Given this list of marker genes Rtel1, Lrwd1, Meaf6, Asf1a, Gtpbp4, Ddx11, Enpp7, Atf1, Noc3l, Etaa1, Ssbp1, Mcm5, Rmi2, Wrn, Tspyl2, Primpol, Poli, Nasp, Rpa2, Mapk15, Cdc6, Tk1, Orc1, Mgme1, Polq, Actl6a, Rpain, Twnk, Brca1, Lig3, Orc6, Prim1, Chtf8, Pclaf, Setmar, Eme2, Gmnc, Rbbp7, Fhit, Nucks1, Mcm4 (minichromosome maintenance complex component 4), Recql, Dtd1, Nuggc, Mus81, Polk, Rad51, Mcrs1, Supt16, Pole4, Upf1, Cdk9, Rfc4, Rad17 (NCBI Gene Id 319242), Ruvbl2, Polg2, Mas1, Ilkap, Cdk2, Ucn, Rny3, Fbxo5, Polrmt, Rtf2, Recql5, Pura, Tipin, Atrx, Chaf1b, Nfrkb, Zpr1, Smarcal1, Mcm10, Yy1, Cenpx, Lpin1, Kat7, Zfp830, Mcm3, E2f8, Fgfr1, Terf1, Tbrg1, Rev3l, Dach1, Rbms1, Mcidas, Atg7, Bod1l, Chtf18, Fbh1, Cdc45, Gins1, Ankrd17, E4f1, Recql4, Pold3, Tonsl, Jade2, Chaf1a (chromatin assembly factor 1, subunit A), Polh (polymerase (DNA directed), eta (RAD 30 related)), Orc5, Wapl, Npm1, Rbbp4, Bard1, Il6, Poll, Npm2, Dna2, Ino80c, Wiz, Pold1, Ctc1, Mcm2, Exo1, Mcm9, Endog (endonuclease G), Dtl, Pole2, Rfc3, Chrac1, Rnaseh1, Gins2, Gli2, Adra2a, E2f7, Ino80, Jade1, Pole, Brca2, Tk2, Jun, Ccne2, Esco1, Orc2, Egfr, Parp1, Ticrr, Ino80d, Zmpste24, Timeless, Dhx9, Exd2, Pds5a, Zranb3, Mcm7, Fen1, Mcm8, Ssrp1 (structure specific recognition protein 1), Wdhd1, Rrm1, Samhd1, Gmnn, Rrm2b, Pcna, Top1mt, Dnajc2, Polg, Aicda, Pole3, Nfix, Gins4, Cdt1, Dbf4, Zfp365, Usp37, Faf1, Nfia, Carm1, Mcm6, Orc4, Dynll1, Nfic, Hras, Ino80e, Mms22l, Met, Ereg, Actr8, Nbn, Inppl1, Rac1, Id3, Cdk1, Gins3, Donson, Cdc42, Orc3, Rad50, Gli1, Stra8, Actr5, Esco2, Dscc1, Khdc3, Lig1, Rfc2, Jade3, Sde2, Obi1, Kin, Rnaseh2a, Kctd13, Mapk8, Wdr18, Sin3a, Wrnip1, Ager, Senp2, Trex1, Grwd1, Ino80b, Eme1, Atr, Ing5, Hcrt, Rmi1, Tnfaip1, Rfc1, Cdc7, Gen1, Rny1, Pold2, Slx4, Cenps, Polb, Ccne1, Dnaja3, Topbp1, Smarca5, Pdgfb, Prim2, Rpa3, Ruvbl1, Mtnap1, Smc3, Atad5, Mettl4, Ttf1, Rpa1, Pola2, Fancm, Rfc5, Ehmt2, Trp53, Stn1, Baz1a, Zbtb38, Poln, Rbbp6, Nfib (nuclear factor I/B), Top1, Rfwd3, Cacybp, Tfpt, Cinp, Ooep, Pola1, Uchl5, Ciz1, Brpf3, Mcmbp, Traip, Helb, Mre11a, Cst3, Ccna2, Blm, Map2k4, Fam111a, Rbbp8, Pold4, here is a description of the gene set: Mouse Gene Set: GOBP_DNA_REPLICATION The cellular metabolic process in which a cell duplicates one or more molecules of DNA. DNA replication begins when specific sequences, known as origins of replication, are recognized and bound by the origin recognition complex, and ends when the original DNA molecule has been completely duplicated and the copies topologically separated. The unit of replication usually corresponds to the genome of the cell, an organelle, or a virus. The template for replication can either be an existing DNA molecule or RNA. species: Mus musculus